The following is a description of a gene set: Human Gene Set: GAUCHER_PBMC_YF_VAX_STAMARIL_UNKNOWN_AGE_7DY_DN Correlates of immune-mediated protection to most viral and cancer vaccines are still unknown. This impedes the development of novel vaccines to incurable diseases such as HIV and cancer. In this study, we have used functional genomics and polychromatic flow cytometry to define the signature of the immune response to the yellow fever (YF) vaccine 17D (YF17D) in a cohort of 40 volunteers followed for up to 1 yr after vaccination. We show that immunization with YF17D leads to an integrated immune response that includes several effector arms of innate immunity, including complement, the inflammasome, and interferons, as well as adaptive immunity as shown by an early T cell response followed by a brisk and variable B cell response. Development of these responses is preceded, as demonstrated in three independent vaccination trials and in a novel in vitro system of primary immune responses (modular immune in vitro construct system), by the coordinated up-regulation of transcripts for specific transcription factors, including STAT1, IRF7, and ETS2, which are upstream of the different effector arms of the immune response. These results clearly show that the immune response to a strong vaccine is preceded by coordinated induction of master transcription factors that lead to the development of a broad, polyfunctional, and persistent immune response that integrates all effector cells of the immune system. Genes down-regulated in peripheral blood mononuclear cell 7d vs 0d in unknown after exposure to YF-Vax/Stamaril, time point 7D studied in species Homo sapiens from publication Gaucher D, Therrien R, Kettaf N, Angermann BR, Boucher G, Filali-Mouhim A, Moser JM, Mehta RS, Drake DR 3rd, Castro E, Akondy R, Rinfret A, Yassine-Diab B, Said EA, Chouikh Y, Cameron MJ, Clum R, Kelvin D, Somogyi R, Greller LD, Balderas RS, Wilkinson P, Pantaleo G, Tartaglia J, Haddad EK, Sékaly RP (PMID 19047440), and this is the list of marker genes: PRKDC, CAMK1D (calcium/calmodulin dependent protein kinase ID), HSD17B11, MTURN, TSPAN5, CA4, TOMM7, RPL27, RPS25 (ribosomal protein S25), ITM2A, PPM1F, BSG, RPS3A, EIF2S3, RPS13, PRDX5, RPS3, QPCT, RPS4X, SRRD (NCBI Gene Id 402055), EEF1A1, CMTM2, SGK1, RPL31, TP53INP2, RGCC, TBL1X, STAT5B, BANK1, DCAF12, RPLP1, FIS1 (NCBI Gene Id 51024), PGLYRP1, RPS20, TPT1, ELAPOR1, RPS8, RPL13, ABCC5, PRDX2, RPL10A, NELL2, CBX7, KLRB1, KBTBD7, RPL3, RPS18, SNRPN, IL1R2, PITHD1, PPBP, MEF2D, GLS, ATM, RPL14, RPS17, CPPED1, PI3, EIF3F, NAMPT, STMN3, RPS23, NAP1L1, ANAPC16, TAGLN2, FAU, MPZL1, FBXO7, MGAM, MKRN1, KLHDC2, RPS27A, MED25 (NCBI Gene Id 81857), RPLP0, RPL37A, DDX3X, VNN2, LDHB, DCAF6, EEF2, RPL11, FAM210B, CD46, ALKBH7, ADGRE3, RFLNB, HINT1, NFXL1, RPL7A (NCBI Gene Id 6130), RPS10, PYGL, RPL18, TOPORS (TOP1 binding arginine/serine rich protein, E3 ubiquitin ligase), RPS29, PHOSPHO1, CYP27A1, PABPC1, GNG10, ORM1, RPL23, LINC00265, TGM3, S100A12, RPS5 (ribosomal protein S5), GMCL1, KLHL2, LMBRD1 (NCBI Gene Id 55788), OSBPL8, DSC2, GLRX5 (NCBI Gene Id 51218), PTOV1, ARAP3, WLS, TMX4, RPL4, RPS6, NIBAN1, FCRLA, SNHG29, CPD, LRRN3, ICAM3, RPS14, H1-2, GPR183, RPL30, PANX2, RUBCNL, TBC1D14, RPL35, RPL13A, CYP4F3, ABHD5 (NCBI Gene Id 51099), PLEK2, SESN3, H4C3, MME, CDK19, NARF (nuclear prelamin A recognition factor), ALPL, ZNF281, CREB5, C12orf57, IL7R, ATOSA, HYCC2, RPL5, RPS24, RPS15A, RNF11, EEF1B2, HECA, APMAP, SLC25A37, RPS6KA5, RPL39, MYADM, RPL9, NPL, RPL35A, SERF2, FOXO1, ABTB1, IMPA2, ERGIC1, SNURF, OSBP2, USP10 (ubiquitin specific peptidase 10), GNG7, PABPC4, PCBP2, EIF4B (NCBI Gene Id 55378), UBE2H, ZNF217, RPL7, MBP, CDC34, BCL6, SLC4A1, TMCO3, EIF3L, SORL1, BTF3, IRS2, PDZK1IP1, PINK1, TXNDC12, AHSP, RPL22, FBL